The following is a description of a gene set: Reactome Pathway: Regulation of expression of SLITs and ROBOs Expression of SLIT and ROBO proteins is regulated at the level of transcription, translation and protein localization and stability. LIM-homeodomain transcription factors LHX2, LHX3, LHX4, LHX9 and ISL1 have so far been implicated in a cell type-dependent transcriptional regulation of ROBO1, ROBO2, ROBO3 and SLIT2. Homeobox transcription factor HOXA2 is involved in transcriptional regulation of ROBO2. Transcription of SLIT1 during optic tract development in Xenopus is stimulated by FGF signaling and may also involve the transcription factor HOXA2, but the mechanism has not been established. PAX6 and the homeodomain transcription factor NKX2.2 are also implicated in regulation of SLIT1 transcription. An RNA binding protein, MSI1, binds ROBO3 mRNA and promotes its translation, thus increasing ROBO3 protein levels. A poorly studied E3 ubiquitin ligase ZSWIM8 promotes degradation of ROBO3. ROBO1 is protein half-life is increased via deubiquitination of ROBO1 by a ubiquitin protease USP33. Interaction of SLIT2 with DAG1 (dystroglycan) is important for proper localization of SLIT2 at the floor plate. Interaction of SLIT1 with a type IV collagen COL4A5 is important for localization of SLIT1 to the basement membrane of the optical tectum. species: Homo sapiens part of: Signaling by ROBO receptors, and this is the list of marker genes: RPL5, RBM8A, RPL28, PSMA3, PSMA2 (proteasome 20S subunit alpha 2), PSMD2, PSMD12, PSMA7, RPS15A, RPL32, UPF3B, MSI1, RPL39, PSMD14, RPL13A, CUL2, RPS9, DAG1, UBB, RPS20, RPL19, RPL10, ZSWIM8, RPL36, RPL26L1, RPS19, PSMA1 (NCBI Gene Id 5682), SLIT1, RPL23, EIF4A3, RPSA, RPS23, RPL27A, RPS27, PSMB6, PSMB7, RPS6, ROBO1, RPS3, RPL36A, LHX4, LDB1 (NCBI Gene Id 8861), RPL10L, USP33, PSMC4, PSMC6 (proteasome 26S subunit, ATPase 6), UPF2, RPS5, RPL22L1 (NCBI Gene Id 553116), PSMB2, PSMC5, RPS4X, UBC, RPL38, RPLP2, ROBO3.1, RPL10A, RPL7A, PSMB4, ROBO3, ETF1, RPS4Y2, GSPT2, RPL27, RPS7, RPS17, RPS12, RPL37, RPL26, ADRM1, RPL15, RPL23A, RPL29, RPS27L, RPS28, RPL3, SEM1, RPS26, RPL36AL, PSMA4, NCBP2, RPL41, HOXA2, RPL37A, PSMD11, ISL1, LHX3, MAGOHB, RPL8, RPL12, ELOB, UPF3A, MAGOH, PSMD6, NCBP1, RPS3A, PSMC2, RPL35A, 5.8S rRNA, RPL35, PSMC1, CASC3, RPL18, SLIT2, RPL3L, PSMA5, RPS27A, ROBO2, RPL14, RPS18, ELOC, PSMB1, RPLP0, RPL34, PSMD3, RPLP1, PSMD7, PSMA6, RPS24, PSMD13, RPL22, RPS11, FAU, EIF4G1, RPL4, RPS15, RPS29, PABPC1, UBA52, LHX9, RPL30, RPS16, RPL39L, PSMB5, RPS8, RPL7, PSMB3, RBX1, COL4A5 (collagen type IV alpha 5 chain), RPL11 (ribosomal protein L11), PSMC3, PSMD8, RPL6 (NCBI Gene Id 6128), RPL31, 5S rRNA, RPS13, RPL17, RPS2, RPL18A, GSPT1, RPS21, RPS10, RPL21, RNPS1, 18S rRNA, RPL13, 28S rRNA, RPL9, PSMD1, LHX2, RPS14, RPS4Y1, RPS25, RPL24